The following is a description of a gene set: studied in species Mus musculus Mouse Gene Set: GOCC_CYTOPLASMIC_SIDE_OF_ROUGH_ENDOPLASMIC_RETICULUM_MEMBRANE The side (leaflet) of the rough endoplasmic reticulum membrane that faces the cytoplasm., and this is the list of marker genes: Rps29, Epm2a, Rpl27, Alg5, Rps28 (NCBI Gene Id 54127), Gnrh1, Rps26